The following is a description of a gene set: The process in which a solute is transported across a lipid bilayer, from one side of a membrane to the other. Human Gene Set: GOBP_TRANSMEMBRANE_TRANSPORT species: Homo sapiens, and this is the list of marker genes: NDUFS7, SLC9C1, KCNA2, PEX6 (peroxisomal biogenesis factor 6, NCBI Gene Id 5190), PEX13, GABRB2, SCN2B, NFE2L2, PEX12, CACNG6, MMGT1, SLC8B1 (solute carrier family 8 member B1), MTCO2P12 (MT-CO2 pseudogene 12), TTYH2, TOMM20L, ANK2, ATOX1, TIMM21, ABCA7, SFXN1, SLC6A11, MAGT1, SLC25A19, PHB2, STING1, TRAM1L1, PSEN2, MFSD3, ABCB4, SLC22A17, NPPA, HTR2B, TCN1, AQP1, TMEM184C, ATP5F1EP2, NNT, SLC35D2, SLC25A5, KCNK13, SLC25A24, CLTRN, NDUFA5, RGS9, KCNJ15, SLC24A1 (solute carrier family 24 member 1), PTPN3 (protein tyrosine phosphatase non-receptor type 3), SLC22A9, SLC25A15, SLC6A8, FLNA, SNTA1, SLC39A4, TMEM163, TMEM144, SLC26A3, MFSD2B, TMBIM1, AQP6, SLC5A11, RGS4, PRKCB, SLC26A6, TRPM1, PCSK9 (proprotein convertase subtilisin/kexin type 9), SLC5A12, PTK2B, ABCB5, CLCNKB, SLC4A11, SFXN3 (sideroflexin 3), ATP8B2, ATP2A3, CREBL2, DNAJC19, GABRB1, SLC11A2, SLC22A8, MT-CO3, STXBP4, SLC15A3, SLC33A1, ABCB7, MCU, DPP6, ORAI1, IBTK, SLC25A26, AQP5, MT-ND4L, NDUFS1, TMEM63A, CD63, SCN5A, SLC24A4, MIP, CALM2, TCIRG1, GPER1, SPNS3, EPO, TAP1, RNF185, TOR2A, PEX1, CCL21, SLC2A3, RHD, TRPM2, SLC44A4, TMEM38A, SELENON, NDUFS3, TMEM63C, SLC51A, HSPA9, ANO9, MIR129-1, SLC39A10, CRBN, MIR448, PEX2, AKAP7, SLC22A1 (solute carrier family 22 member 1), ATP5F1B, DDIT3, HVCN1, KCNJ12, SLC25A37, KCNJ9, SLCO3A1, TRPM4, SLC6A15, ATP5F1A, CHD7, GSDMB, MT-ATP8, ATP7A, SLC18A3 (solute carrier family 18 member A3), NEDD4L, AQP7, CALM1, ANKH, S100A6, ABCA6, MCOLN1, SLC17A4, COX5B, NALF1, XCL1, TIMM44, TRPV5 (transient receptor potential cation channel subfamily V member 5), SLC16A10, SLCO5A1, COL6A1, SCNN1D, JPH1, SLC38A4, SLC48A1, MIR326, INS, SLC1A3, AKAP5, HSP90AA1, CLDN3, SLC4A2 (NCBI Gene Id 96677), CHERP, KCNRG, TRPV4, ATP6V0E1, SLC22A24, SLN, TMC5, EXOC7, MT-CYB, MIR185, NDUFS6, ATP2A1, CLCN5, STEAP2, ARL6IP5, PIEZO1, CHRNB4, PLCB2, SLC35E3 (solute carrier family 35 member E3), SCN4A, CAV1, SLC37A3, CLIC2, STRA6, KCNE2, GABRB3, ADCYAP1R1, KCNK10, PKDREJ, ACSL1, DIAPH1, SLCO1C1, SLCO1B3-SLCO1B7, ATP1B1, SLC4A9, GRIN2A, MIR26A1, NDUFA1, OPRM1, SLC12A4, TMCO3, LETM2, MIR451A, CD36, SLC39A11, FXYD7, MIR328, SLC2A13, SLC25A10, PKD2L2, ACACB, SLC47A1, AZIN1, LRRC26, CLCNKA, ABCB11, CCR7, CACNA1I, TRPC4AP, LARGE1, SLC17A5, KCNN1, SLC5A3, CNNM3, TPCN2, JPH4, GRP, CXCR3, MS4A1, VMP1, PLCL2, RNASEK, ABCB6, TOMM40L, KCNJ18, NDUFA10, GJB7, CACNA1G (calcium voltage-gated channel subunit alpha1 G), SLC35F6, SCN10A, AKAP6, FKBP1A, SLC22A6, MCUR1, TRIB3, ABCC2, SLC25A52, CD4, SLC12A1, TMEM184A, SLC2A9, SLC5A8, GABRD, TMC8, SLC35C2, SVOPL, SLC39A12, SCN4B, ATP1B2, PEA15, DRD1, PIEZO2, AP4M1, PIK3R1, CACNG1, SLC7A5, SLC23A3, CRHR1, KCNQ5, CHRNG, SLC30A5, MIR208A, HTR3C, PPIF, SMDT1, SLC15A2, SLC51B, RAB4B, GJA4, SLC16A11, GLRA2, TRIP11, KCNK4, SRP54, SLC3A2, ANO3, HCN2, MT-ND3, TMBIM6 (NCBI Gene Id 7009), SLC4A10, STAC2, SLC5A6 (NCBI Gene Id 8884), ATP5PB, SCN9A, KCNK18, TMEM44 (transmembrane protein 44), MPV17, SLC6A13, SLCO1B1, SLC24A2, GNB2, CHCHD4, MIR133A1, UQCRFS1, ATG5, ABCC12, KCNG3, GP5, OCLN, SLC25A32, BLOC1S6 (biogenesis of lysosomal organelles complex 1 subunit 6), PLCG1, SLC22A10, COX17, PACC1, CLCA1, PRKD1, GOPC, ATP6V0A4, ATP2A2, SLC39A13, SLC2A4, SEC63, RHCE, AKT2, SLC38A11, CXCL10, PAM16, SLC17A3, C2CD5, CHRNA6, NDUFV1, DNLZ (DNL-type zinc finger), SLC16A14, TMEM165, DAPK1, ATP6V1B1 (ATPase H+ transporting V1 subunit B1), SLC39A1, SLC31A2, IFNG, VAMP2 (NCBI Gene Id 6844), REM1, TTYH1, ATP5PF, ATP5F1E, ATP5MC3, SLC2A2, NDUFA12, CALHM2, SLC17A7, PPP3R1, PLCB3, SLC2A7, HTR2A (NCBI Gene Id 3356), CACNA2D3, PLCG2, GJB6, SLC13A2, LRRC8C, KCNMB4, SLC25A12, OPRK1, CYBB, FGF19, MIR93, DRD2, GJC1, SLC39A6, KCNAB1, HEPH, HPSE, KCNK6, RSC1A1, P2RX4, SLC25A25, WNK1, NDUFC1, TCAF2, MCUB, SLC6A6, FFAR4, ATP5F1C, CACNB2 (NCBI Gene Id 783), CORO1A, TRPC6, FGF21, SLC19A3, SLC1A7, SLC25A48, ABCA3, CHRNB2, NR4A3, GRINA, BHLHA15, RYR2, GABRG1, SHROOM2, SLCO1B7, CLTCL1, GRIN3B, SCNN1G, SCARA5, FXYD3, KCNC2, MFSD10, KCNIP3 (NCBI Gene Id 30818), MT-ND4, CHRNB3, STRIT1, MFSD14CP, KCNH7, PPARD, GJC3, NDUFC2, MIR21, KCNF1, GABRA6, CLIP3, ATP11C, TNF, GRIN2B, CACNA2D1, SESTD1, MFSD4A, CPT1B, WNK4, ATP6V0A2, SLC6A19, TOMM40, MMP9, KCNE4, KCND1, ARPP19, CNGA4 (NCBI Gene Id 338753), SLC6A17, SLC38A6, SLC30A4, ABCG1, SLC6A3, NGF, SLC7A7, CLN8, COX7B, TRPA1, SLC25A13, TMEM109 (transmembrane protein 109), TMED10, GSTM2, FXYD1, CCL3, SLC39A2, SLC8A1, SLC25A21, TRPC7, NDUFS4, P2RX5, GRID2, BLOC1S3, ACE2, SCN11A, SLC1A2, SLC25A4, TESC, TRPC5, DCD, SLC27A1, SLC25A11, SLC16A9, ABCC11, KCNS2, GABRA1, SLC25A22, CYBRD1, SLC2A12, CHRFAM7A, FGF13, EDN1, GRIA2, SLC35E1, TAP2, HTR2C, ATPSCKMT, CTSS, CPT1A, SLC13A4, PPP3CC, CX3CL1, GRIK1 (glutamate ionotropic receptor kainate type subunit 1), PDE4B, HCN1, SLC25A47, GNB5, CHRNB1, MT-CO1, ATRAID, CCR5, SLC22A20P, GLRA1, GFER, CAPN3, SLC12A2, KCNT2, CLN3, HAP1, SLC9A5, KCNN3, KCNS1, CNNM2, CLCN4, SLC9B1, TRPC3, SLC34A2, SLC22A16, NDUFA7, ATP6V0B, ABCC10, ANO5, ANXA6, NALCN, EDNRB, SELENOS, CLIC6, NDUFB2, CNGA1, SLC17A2, KCNAB2, SLC38A7, F2R, RACGAP1, TOMM7, CNGB1, GAS6, MFSD9, CNGA3 (cyclic nucleotide gated channel subunit alpha 3), SLC25A41, FABP5, JPH3, OSTN, SV2A, ATP8A1, YES1, KCNA7, RAB11A, SLC22A31, SLC10A4, LACRT, STIMATE, SLC6A5, GRPEL2, RALBP1, SLC12A3, GSK3A, PPP3CA, SLC2A10, CALHM4, CCL19, AHNAK, ATP1A3 (NCBI Gene Id 95633), SLC46A2, GJB5, PLCB1, OAZ1 (ornithine decarboxylase antizyme 1), BEST2, SLC38A3, GABRG2, SLC4A1, SLC46A3, KCNJ3, SCARB1, CYB561D2, LASP1, PLP2, SLC35E2A, LRRC8D, GLRB, LRRC8B, GABRR1, SLC5A1, SLC36A2, CD19, ACSL5, PRAF2, SLC1A1 (NCBI Gene Id 6505), SLC35E2B, SLC22A18 (solute carrier family 22 member 18), GABRA5, AQP9, PANX1, SLC7A8, SFXN2, HSPD1, TRIM37, KCNB2, SURF1, NIPA2, ATP6V0D1, SLC26A1, LRRC55, SLC27A4, TMSB4X, SLC5A4, GAL, PRKCE, SEPTIN2, LYN, CFTR, CAB39, CLIC4, PEX5, SLC1A5, EDN3, KCNJ1, KCNJ14, BRAF, TMC1, CLCC1, RNF5, SLC25A45, SLC22A7, NOL3, PKD1L3, AMIGO1, ATP13A4, NIPAL2, SLC9B2 (NCBI Gene Id 133308), ITGAV, TMEM184B, PDZK1, CEMIP, ATP1A1, SCNN1A, PKD2L1, TMEM94, ATP1B3, GABRA2, CATSPER1, SLC16A2, CALHM1, HNF1A, CACNA1B, STXBP3, CACHD1, CACNG2, PLCH1, SLC6A12, COX4I1, SLCO1A2, GJA1 (gap junction protein alpha 1), SLC25A31, ADIPOQ, SLC10A2, FAIM2, CLCN6, HAMP, IL13, ATP6V1A, SLC35A1, SLC25A27, MFSD14A, ABCB8, SLC9A8, ABCG5, KCNA10, GJA3, CYB561A3, IRS2, SLC25A53, CLCA2, GPR155, AGT, ORAI3, VDAC3, TMEM30A, ABCA2, PLN, LCN2, NOS1AP, MIR499A, SLC41A3, GC, CLDN17, SLC2A8, SLC28A3, TOMM20, SLC2A1, SLC22A25, ATP6V1G3, AQP2, CATSPER4, FLVCR2, PDPK1, KEL, KCNMB2, SLC24A5, SLC49A3, FASLG, HPN, SLC22A11, TUSC3, TMEM175 (NCBI Gene Id 84286), TIMM17B, GRIA3, CLCN2, P2RY6 (pyrimidinergic receptor P2Y6), CHRNA4, DPP10 (dipeptidyl peptidase like 10), FHL1, SLC16A4, SLCO1B3, AIFM1, PPP3R2, CACNA2D4, SLC25A2, GRB10, ATP13A3, ATP6V1F, CASQ1, NDUFA6, SLC34A3, AQP10, SLC38A10, VDR, SLC66A1, TGFB1, GABRG3, CPT2, SLC22A5, PMPCB, ASIC1, AHCYL1, GSDMA, SLC35A2, SNAP25, CATSPER2, ABCB10 (NCBI Gene Id 23456), C3, SLC9B1P1, PEX16, MIR873, LIME1, NDUFB7, KCNIP1, G6PD, SPNS1, SLC7A1, SLC25A33, CATSPER3, NIPAL3, SLC36A3, INPP5K, RGS2, MIR133B, ISCU, CRH, LRRC8E, WNK3, SLC44A3, SLC35D1, SLC6A18, KCND3, UCP1, SLC5A5, CDH17, RHBG, SLC12A9, TMEM241, CAPN10, SLC12A6, ATP1A4, SLC38A8, BOK, UQCRH (NCBI Gene Id 7388), SLC1A4, SLC30A1, SEC61G, KCNU1, SLC4A7, SLC26A9, PTH, ATP13A1, MICU2, CACNA1D, P2RX6, SLC50A1, RYR1, CHRNE, ZFAND2B, GRM6, FLVCR1, SLC22A12, NDUFA2, MIR29B1, SORBS1, ANO6, TCN2, SLC9A3, SLC66A1LP, ATP1B4, ERFE, CACNG4, SLC7A5P2, SLC18A1, SLC6A14, ITPR1, CHRNA7, WWP2, KLF15, MT-ND6, BEST1, SLC20A2, SLC7A6, KCNA6 (NCBI Gene Id 3742), NDUFS2 (NCBI Gene Id 4720), MIR212, EDNRA, SLC4A4, ATP6V1D, WNT3A, TTYH3, TSPAN13 (tetraspanin 13), CACNG7, GRM1, KCNE1, PTPN6, SLC38A1, MFSD14B, ATP6V0E2, STIM1, CACNG5, KCNA3, MPC1, UTRN, GABRR2, GJB3, MPEG1, SLC22A3, MFSD12, SLC14A1, IGF1, MICU3, DMAC2L, KCNN2, ATP1A2 (NCBI Gene Id 93186), EPM2A, CHRNA2, SLC35B2, MIR508, SLC29A2, MFSD4B, ASPSCR1, GRIA4, ATP13A5, AZIN2, SLC7A11, ATP6AP2, ERO1A, SLC6A2, KCNE5, SLC5A10, KCNK3, ATP2B4, ABCD1, PEX7, ADCY10, VDAC2, TRPC4, SLC32A1, TRARG1, SLC27A5, ANO10, ITPR2, RTN2, KCNQ3, MIR30D, SLC45A4, PRKCI, SLC2A14, ABCB9, SLC17A8, MRS2, SLC25A29, KCNT1 (NCBI Gene Id 57582), FYN, ABCC1, TRPM6, SLC44A2, P2RX1, USP9X, SLC28A1 (NCBI Gene Id 9154), FGF12 (NCBI Gene Id 2257), STAC3, GLP1R, PEX10, MCOLN2, WWP1, HTT, CACNB3, NDUFB4, LRP2, CALM3, TMCO1, OPN3, MT-ND1, WNK2, AQP12B, KCNJ6, KCND2 (potassium voltage-gated channel subfamily D member 2), ABCG2, MEF2A, PRNP, ABCC8, ATP6V1C1, ATP10D, HTR3E, CALHM6 (NCBI Gene Id 441168), KCNMB1, KCNK17 (NCBI Gene Id 90081), TIMM17A, EXOC4, SLC43A3, CLCN1, SPNS2, RHCG, SLC35A3, DTNBP1, NIPAL1, MIR208B, DMD, GPR89A, UBQLN1, GRIK2, SLC46A1, ABCC9, SLC8A3, FXYD2, FXYD5, CBLIF, SLC7A3, CUL5, SLC12A5, BIN1, SLC3A1, KCNJ13, MIR192, ZDHHC13, ATP6V1G1, SLC2A5, KCNA4, ATP12A, P2RX7, TMEM37, THY1, MIR34A, EMB, ATP6V1E1, SLC9A6, SCN1B, CASQ2, CD2AP, TERT, SLCO2B1, ATP5MC2, PID1, SLC2A6, SLC39A9, CLIC1, PTPRM, SLC45A3, COX7A2L, VDAC1, KCNJ4, ABCC5, RNASEL, ATP5MG, SLC30A8, SLC7A14, SLC29A3 (NCBI Gene Id 8072), RHAG, MIR495, MT-ND2, SNCA, NDUFV2 (NCBI Gene Id 4729), STK39, PANX2, TIMM23B, SLC49A4, AQP3, SLC25A3, DNAJC15, SLC25A18, GJA10, CTNS, SLC40A1, BEST3, OAZ3, CHRNA1, ATP6AP1, SCN7A, SLC7A5P1, SLC5A9, ROMO1, APP, MIR143, SLC22A14, TRAM1, ANO2, AQP12A, SLC35D3, SLC25A30, ASIC3, YWHAE, SLC10A3, GABRQ, SLC15A4, APPL1, GPC3, ASIC2, MAIP1, FGF2, ABL1, TRPM5, KCNJ11, CCDC51 (coiled-coil domain containing 51), SLC35B4, TMBIM4, TRPV3, SLC29A1, CALHM3, MICU1, TPCN1, KCNIP4, GRIK5, BAX, ATP6V0A1, SLC1A6, ARL6IP1, KCNB1 (potassium voltage-gated channel subfamily B member 1), LRRC8A, ABCB1, SLC24A3, PEX14, ATP10A, SLC37A1, XPR1, NEDD4, NTSR1, CLIC3 (chloride intracellular channel 3), NALF2, SLC5A7, ABCD2, HSPA5, TPTE2, SLC25A39, MIR24-1, ATP13A2, SLC35C1, ATP6V1E2, NDUFB10, FMR1, NDUFA8, ATP2B1, SLC37A2, NDUFS8, CYBA, KCNQ1, SLC9A4, SLC37A4, SLC45A1, KCNJ2, HCN3, STOM, FXYD4, PLCL1, HCN4, SLC7A10, ATP6V0D2, ABCA1, TRPM8, MFSD2A, MPC1L, ENPP1, CNNM4, CNGA2, SLC11A1, RAP1A, KCNV2, KCNK9, SLC22A15, CLCA4, SLC26A7, BAK1, SLC35G1, GJC2, SLC18B1 (NCBI Gene Id 116843), TRPC1, SCN3A, SLC38A5, SLC25A38, FXYD6, F2, KCNAB3, RHOQ, PER2, KCNV1, NHERF1, MT-ND5, CAV3, SLC26A5, ITGB1, GH1, SLC43A1, KCNK16, SHOC2, SLC16A3, XCR1, CLDN16, SEC61A1, NDUFB8, COX7A1, SLC6A16, POU4F2, TMC7, PANX3, COX8A, CACNA1C, KCNJ10, TRPM3, OTOP3, IRS1, SLC25A17, CACNA1F, SLC25A16, SAMM50, SGCB, SLC13A5, PIK3CG, TRPM7, HTR3A, GPM6A, SLC23A2, TMC6, SLC7A2, ASIC5, GRIN3A, CHRND (cholinergic receptor nicotinic delta subunit), SLC16A1, CLCN7 (NCBI Gene Id 7814), APOL1, ATP5MGL, UQCR10 (ubiquinol-cytochrome c reductase, complex III subunit X), GJA8, AQP7B, SCN3B, COX6B1, CHRNA5, ABCC4, GRXCR1, GP1BB, SLC7A9, SLC22A13, SLC17A6, SLC39A7, GRIN2C, ABCA9, PTPRC, SLC43A2, NDUFB5, KCNK15 (potassium two pore domain channel subfamily K member 15), ABCG4, MCL1, CACNG8, LEP, SEC62, SLC16A7, SLC6A4, CRACR2A, SLC10A7, ANO1, SLC44A1, KCNJ8, ABCC6, PKD1L1, KCNJ5, NOS1, ATP6V0C, SLC25A23 (solute carrier family 25 member 23), GALR2, SPHK2, ITLN1, HPCA, SLC35F1, SLC30A9, MRPL18, SLC22A4, SLC23A1, NDUFA3, GFAP, SLC39A14, ATP5PO, ABCA10, TMC2, PTPN11, LRP6 (LDL receptor related protein 6), SLC39A8, SLC4A8, ANO8, SLC26A11, ITPR3, TMC3, GRIN1, PPP3CB, NDUFA4, SLC45A2, SLC13A1, LCK, PEX5L, GPR35, ATP5MF, MT-CO2, APPL2, TMEM150C, ABCA12, THBS1, GJE1, SLC7A4 (NCBI Gene Id 96585), CNNM1, MFSD1, CXCL11, SEC61B, GRPEL1, SCN1A, KCNA1, AP3D1, NPSR1, SLCO4A1, MIR103A1, ABCD4, OSR1, SLC12A7, SLC12A8, SLC25A42, CACNA1H, KCNH1, GRIA1, SLC30A3, ABCA5, CA2, SLC9A1, ORAI2, BDKRB1, SLC35B1, ATP5PD, SLC36A1, GABRP, CACNA1E, APLNR (apelin receptor), CLDN4, CACNB4, CHRNA9, SLC25A51, SLC26A2, KCNMB3, SPG7, GABRR3, SLC15A5, SLC34A1, GJB4, ATP6V1G2, ATP2C2, ATP5ME, GRID1, SLMAP, SLC17A9, CRHBP, ANK3, OCA2, MIR1-1, GRIK3, SEC61A2, PRRT1, BCL2L1, KCNC4, SLC35F2, SCN2A (NCBI Gene Id 94312), SLC25A40, KCNC1, ATP11B, OTOP2, ITGB3, SLCO2A1, NDUFS5, KCNH2, BCL2, CHRNA10, PLA2G1B, OXSR1, ABCD3, LRRC38, NDUFA9, SLC25A43, KCNS3, OAZ2, KCNG4, CLCN3, BEST4, SLC35A4, SLC35A5 (solute carrier family 35 member A5), ATP8B1, IFT20, MT-ATP6, DLG1, TMEM38B, NOX5, SLC25A28, GP1BA, CBARP, CCT8L2, CALHM5, PPBP, CTNND1, SLC6A20, SRI, SCNN1B, TMEM120A, KCNC3, PLCH2, ASPH (NCBI Gene Id 56921), SFXN4, GJB1, KCNH4, RYR3, SLC16A8, SLC18A2, GJB2, SHISA7, NDUFB1, GSDME, SLC9A7, GABRA4, MIR223, ATP6V1H, SLC35E4, CACNA1S, KCNK12, P2RX3, INSR, UBR3, ABCC3, CNGB3, SLC10A6, SORT1, TOMM22, AFG3L2, MIR210, SLC41A1, CERS1, KCNH8, ZDHHC7, SV2C, GJD3, MIR200C, OSBPL8, MIR34B, SLC16A5, TOMM70, TRPV6, SLC16A13, SLC13A3, AQP4, NIPAL4, SLC9A2, MIR9-1, SLC19A1, CAMK2D, PKD2, LETM1, AQP11, TIMM50 (NCBI Gene Id 92609), HSPA4, SLC6A9 (solute carrier family 6 member 9), ACTN4, BCR, KCNK1, C1QTNF12, CACNB1, JPH2 (junctophilin 2), SLC25A20, MIR186, ABCA13, PIM1, PLCE1, OSCP1, UQCRFS1P1, MINK1, KCNH6, SCN8A, PKD1, AZGP1, SLC19A2, TRDN, NCS1, ANO4, KCNA5, PRKAG2, GABRE (NCBI Gene Id 2564), ATP5F1D, SLC7A13, HTR3B, YWHAQ, TSPO2, ZACN, CNIH3, SIRT6, SLC26A10P, GSDMD, ATP5MC1, KCNN4, F2RL3, NMUR2, SLC39A5, ATP2B2, HRC, GABRA3, ATP6V1C2, UCP3, SV2B, AKT1, BPIFA1, LONP2, SLC26A8, SLCO4C1, SLC38A2, POU3F3, ABCA4, SLC22A2, ABCA8, KCNG1, CLIC5, SLC44A5, SLC36A4, SLCO6A1, GPR89B, SLC47A2, COX5A, OTOP1, STAC, NDUFB9, HK2, CYB561D1, SLC16A6, RBP4, GJA5, KCNH5, SLC6A7, BCL2L10, ATP2B3, TMC4, SUMO1, ABCG8, SFXN5, SLC10A5, PKD1L2, SLC19A4P, SLC14A2, PDE4D, KCNK7, CHRNA3, GJD4, GLRA3, TRPV1, CACNG3, KCNK2, PNPT1, SLC25A6, LRRC52, MPC2, TCAF1, SLC28A2, NDUFB3, UQCRC1, TIMM22, ATP7B, BCL2A1, UNC80, SLC4A5, IL1B, TIMM23, COMMD1, SLC30A7, UCP2, FKBP1B, DHRS7C, SLC26A4, KCNE3, PRF1, SLC6A1, TMEM63B, UBASH3B, TST, GRIN2D, SLC10A1 (solute carrier family 10 member 1), MAPK14, SLC22A23, CHP1, SLC9C2, SLC25A1, ANO7, ATP4B, GHITM, GJD2, KCNG2, PML, CALCA, PEX26, TLR9, TSC1, SLC17A1, SLC30A10, GRIK4 (glutamate ionotropic receptor kainate type subunit 4), MIR107, CTTNBP2NL, ATP2C1, KCNK5, CACNA1A, ASIC4, PLCB4, ATP4A, CACNA2D2 (NCBI Gene Id 9254), SESN2, KCNH3, PSEN1, SLC25A36, SLC16A12, MFSD8, KCNQ2, SLC9A9, KCNMA1, STIM2, SLC8A2, SLC41A2, GSDMC, SLC31A1, CNIH2, NDUFV3, GP9, GSTO1, NIPSNAP2, SLC30A2 (NCBI Gene Id 84555), ATP6V1B2, ACTN2, MCOLN3, SLC4A3, SLC29A4 (NCBI Gene Id 222962), GJA9, SLC2A11, P2RX2, KCNQ4, METTL21C, NIPA1, KCNJ16, KCNIP2, AQP8, CXCL9, SLC39A3, TRAM2, SLC25A14, TRPV2, BSND, PRKACA, SLC20A1 (NCBI Gene Id 6574), BCL2L2, SLC35B3, TPTE, CASR, UMOD, SLC25A44, SVOP, CYC1, SLC38A9, FXYD6P3, NDUFB6, SLC15A1, SLC30A6, SLC5A2, HTR3D, RANGRF